Given this list of marker genes Htra2, Rpl23 (NCBI Gene Id 80497), Otub1, Rpl11, Rps20, Fbxo5, Spry2, Glmn, Park7, Cdkn2a (cyclin dependent kinase inhibitor 2A), Rps7, Rps15, Rpl37, Limk1, Rpl5, Gbp4, Rpl37rt (NCBI Gene Id 100502825), here is a description of the gene set: studied in species Mus musculus Binds to and stops, prevents or reduces the activity of a ubiquitin-protein transferase. Mouse Gene Set: GOMF_UBIQUITIN_PROTEIN_TRANSFERASE_INHIBITOR_ACTIVITY